Given this list of marker genes Gm5507, Neil3, Hmgn2, Rev1, Zranb3, Bex2, Sncb, Mpp2, D430020J02Rik, Gm22888, Kcnh7, Mcm3, Trp53bp1, Rufy3, Arhgap11a, 4930579G24Rik, Timm50, Zfp239, Tmem132a, Cep85, Mir344c, Rad54b, Aldh1l2, Gm12610, Tdrkh, Hmgb2, Kif20b, Rtel1, Kpna2, Cdca5, Ints7, Pigf, Cibar1, Brsk2, Bcl7a, Ap3b2, Nrm, Agpat5, Trp53i11, Cdc45, Nme1, Fancm, H4c12, Ccdc112, Celsr2 (NCBI Gene Id 53883), Simc1, Chaf1a, H1f5, Myo19, Mtcl3, Ncapg2, Chrnd, Abhd6 (NCBI Gene Id 98228), Fsd1, Jakmip2, Shisa4, Tsn, Rev3l, Cdca8, Cdc25a, Nasp, Nfasc, E2f8, Cenpe, Tonsl, Ndc80, Gm5327, Fancd2, Nup188, Pask, Shcbp1, Yars1, Slc25a4, Mis18bp1, Macrod2, Lrrc40, Rrm1, Sae1, Melk, Ctdspl2, Cpt1c, Dbf4, Eri1, Cnot9, Ddx11, H2ac20 (NCBI Gene Id 319176), Gp1bb, Kif11, Sstr2, Fam120c (family with sequence similarity 120, member C), Plxna3, Cdk1, Mbd4, Prox1os, Pfn2, Ckap2, Pold3, B4galnt4, Aspm, Pgp, Gm16494, Plppr4, Hyls1, Pif1, Dhx9, Brip1, Cdkn2c, Scg3, Tpx2, Cbx6, Ptprn, Rims2, Hmmr, Pold1, Cdkn2d, Mcm6, Rfc5, Pole, Slc35g1, Mir344-2, B930095G15Rik, Gm25432, Rps6kl1, Bdh1, Arfgef3, Lig1, Pmf1, Syce2, Rpa1, Thoc7 (THO complex 7), Adgrb2, Odf2l, Zfand4, Mtf2, Gas2l3, Uhrf1, E2f7, Paxip1, Lhx2, Synpr, Med14, Hells (helicase, lymphoid specific), Pagr1a, Ccne2, Acsl6, Fbxl16, Plk4, Sox12, Cdkn3, Mad2l1, Nuf2, Sox2, Scg5, Ccnb2, Donson, Ubr7, Cdh2, Sez6, Trim37, Gm6625, Hdac3, Ilf3, Dhrs13, Parpbp, Clcn2, Brca2, Foxm1, Cdk2, Dck, Sanbr, Gm13421, Celsr3, Tubgcp2, Ppp2r2c, Cd276, Flywch2, Gm6594, Firrm, Rad51, Tmx1, Cks2, Hint1 (histidine triad nucleotide binding protein 1), Gtf2a2, Smyd4, Tmpo, Tafa4, Cacna1b, Wdr6, Nrsn1, Kif20a, Rfc4, Slc9a5, Jazf1, Kntc1, Syt2, Ccp110, Slc36a4, Gpr173, Tmx4, Gins2, Ttc3, Atp6v0e2, Mcm7, Incenp, H2ac7, Exo1, Vwa5b2, Ppfia3, 2410002F23Rik, 1500009L16Rik, Cep55, Slc6a17 (NCBI Gene Id 99905), Hjurp, Tox, Pkmyt1, Pcbp4, Mapk8ip1, Kif2c, Mmp24, Tfdp1, Ncaph, Unc79, Nrxn1, Srrm3, A230057D06Rik, Cdc25c, Aurka, Cdt1, Coprs, Pdzd4, Entrep3, Ppat, Cdc6, Ccne1, Ranbp1, Rundc3b, Sfxn1, Dcbld2, Uba2, Eid2, Dnmt1, Chaf1b, Gtse1, Rnaseh2b (NCBI Gene Id 68517), Strbp, Prc1, Tpi1, Nmral1, Ahi1, Myb, Myef2, Herc3, Ung, Dock3, Mthfd2, Psip1, Ttc8, Ptprn2, Acvr1, Slc4a8, Pmm1, Ska2, Sephs1, Syt13, Tmem178b, Gm3373, Racgap1, Dtl, Tdg-ps2, Celf4, Kif14, Pcna, Slf1, Asphd1, Tyms (thymidylate synthase), Ptn, Macroh2a1, St18, Slc38a2, Cbx3-ps6, Fanca, Nt5c2, 3000002C10Rik, Nrcam, Atp5if1, Lmo1, Kif23, H2bc13, Syt9 (synaptotagmin IX), Stau2, Pcdhb21, Mboat2, Chgb, Mrps16, Adgrb1 (NCBI Gene Id 97994), Ticrr, Mif, Rundc3a, Eef1ece2, Slain1, Sass6, Scai, Reep2, Mybl1, Hnrnpd, Snrpd1, Arhgef39, Pkm, Msh6, Cenpi, Mcm4 (NCBI Gene Id 17217), Smarcc1, Iqgap3, Srsf1, Cacnb3, H2ac10, Ric3, Dna2, Bex3, 6030442K20Rik, Smc5, Pold2, Prkcb, Anln, Scrn1, Aldh18a1, Klhdc2, Gpr19, Fam216a, Ckap2l, Sbk1, Xrcc6, Caskin1, B4galt6, Gpr37l1, Stx1a, Ctps1, Mir344, Cdk5r1, Mcm5, Gmnn, Prim2, Larp7, Oxct1, Ahcyl, Samd14, Dclk2, H2bc3, Senp1, Cfap20dc, Prelid3b, Pcdhb18, Kcnb2, Myt1, Bub1b, Ankrd28, Suz12, Hmgn2-ps, Rad54l, Nbea, Trpc2, Zfp599, Cadm4, Klhdc10, Rgs17, Kif18a, Morn4, Cenpa, Rad18, Cenpq, Cdkn2a, Syt14, Prox1, Chga, Bicd1, Cisd3, Ppme1, Clspn, H4c18, Gm10313, Zfp382, Blm, Rnu1b1, Ran, Trip13, Nucks1, Eef1a2, Nono, Cdc20, Cep295, Vash2, Nup205, Ncam1 (neural cell adhesion molecule 1), Hirip3, Strip2, Stxbp1 (syntaxin binding protein 1), Ncapd3, Ckap5, Rpa2, Gm10053, Chd7, Pola1, Cntrob, Cenpv, Gpr139, Psd, Clec2l, Kif1a, Nipsnap1, Meaf6, Phtf1os, Slbp, Ttc39aos1, Gapdh-ps15, Rtn2, Kif5c, Ephb2, Hap1, Plppr1, Cspg5, Pidd1, Atad2, Tex9, Cand1 (NCBI Gene Id 76147), Umps, Tube1, Gnaz, Fgf14, Bora, Fanci, Zwilch, Sesn3, Ube2c (ubiquitin-conjugating enzyme E2C), Lhfpl4, Troap, Sfmbt1, Hdac9 (NCBI Gene Id 79221), Tubb5, Rfc1, Srd5a1, Trim59, Ptprz1, Fxyd6, Maged1, Atad5, Msh3, Tmem199, Zfhx2os, Plk1, Gm24837, Sgo2a, Zfp948, Pbk (PDZ binding kinase), Ankrd13b, Elavl3, Dut, 5330434G04Rik, Zgrf1, Gm23293, Ccnb1-ps, Ska3, Cenpl (centromere protein L), Gm22806, Kif22, Lin9, Stil, Spdl1, C2cd5, Snap91, Smarca1, Lrp11, Matcap2, Wdr76, Syt1, Stmn1, Aurkb, Rbm15b, Knstrn, Ska1, Six4, Trmt6, Dhfr, Camsap1, Ncbp1, Gspt2, Cenpm, Rcor2, Phf6, Neurl1b, Ehbp1, Cdk4, Nsd2 (nuclear receptor binding SET domain protein 2, NCBI Gene Id 77281), Map9, Sclt1, Pcyt1b, Aplp1, Morf4l2, Cenpu, Alms1, Apoo, Rbl1, Nphp1, Elapor2, Mapk8ip2, Sarm1, Hsf2, Ina, Uchl1, Abi2, Supt16, Nup155, Smc2, Dpysl5, Tubg1, Gins1, Prr11 (proline rich 11), Cstf2, Map7d2, Hes6, Ints2, Ralgps1, Gm57857, Arhgap19, Zbtb41, B3galnt1, Usp37, Rbfox2, Ezh2, Foxred2, Galnt9, Smc4, Abat, Hook1, Zfp60, G2e3, Scamp5, Depdc1a, Ccser1, Pcdhb17, Mcm2, Zfp114, Prrt3, Faxc, Orc2, Tlcd3b, H1f10, Mki67, Greb1l (NCBI Gene Id 381157), Sez6l2, Cacna2d3, Cbx5, Lancl2, Phyhipl, Th, Zbed3, Fam83d, Ift80 (NCBI Gene Id 68259), A330076H08Rik, Atcay, Fignl1, Gmps, Rgs16, Ctnnd2, Hnrnpa3, Gm6669, Arnt2, Hmgn3, Pcbd1 (pterin 4 alpha carbinolamine dehydratase/dimerization cofactor of hepatocyte nuclear factor 1 alpha (TCF1) 1), Ccnb1, Rimkla, Ddc, Ssrp1, Crmp1, Cenpn, Rnf126, H2bc4, Socs7, Tmem181a, Wnk2, Spag5, Grik5, Ccna2, Kif4, Cdk5rap2, Kifc1, Cenpk, Ccdc138, Pttg1, Parp6, Slc38a1, Ncapd2, Gm5577, Sumo3, Pcsk1, Gm21963, Zkscan2, Fbxo44, Cenpf, H3c3, Irak1bp1, Ccdc18, Tmtc4, Zdhhc2, Casp3 (NCBI Gene Id 12367), Ranbp17, Top2a, Syp, Polr3h, Arc, Birc5, Fmn2, Mtmr7, Exog, Nsl1, H2ac22, Ulbp1, Slc8a1, Helq, Rif1, Dis3, Phf19, Topbp1, Rangap1, Phc1, Orc6, Gm25552, Six1, Tacc3, Foxk2, Ttk, Sertad4, Chn2, Fbxo2, Prmt1, Sobp, ENSMUSG00000134155 (novel transcript, antisense to Nrg3), Cdc25b, Pnma8a, Zfp512b, Gm23557, Rfx3, Sel1l3, Tbc1d24, Depdc1b, Fcho1, Tmem130, Nusap1, Prim1, Dot1l, Bzw2, Pcm1, Gpr75, Nat14, Ncapg, Kdm1a, Kif18b, Gpld1, Dlgap5, Ect2, Gdpd1, Ppip5k2, Jpt1, Efs, Gm3095, Gpr162, Slc7a14, Tipin, Idh3a, Nexmif, Slc45a1, Ano8, Ccn3, Cstf3, Mms22l, Nop58, Plppr2, Ctc1, Maneal, Rcc2, Cenph, Dner, Sgo1, Zdhhc15, Pdxp, Npat, Chrnb2, Rbm15 (NCBI Gene Id 229700), Ptpdc1, Cdkn1a, Wdhd1, Gprin1, Lockd, Pcgf6, Fsd1l, H2ac11, Gen1, Scn8a, Spc25 (SPC25, NDC80 kinetochore complex component, homolog (S. cerevisiae)), H1f0, Cdca2, Rab39b, Gdap1l1, Mir344h-1, Map3k12 (NCBI Gene Id 26404), Rnf112, Nek2, Cdc7, Rragb, Sqle, Chek1, Knl1, Arhgap20, Ipo5, Bok (BCL2-related ovarian killer), Gm23294, here is a description of the gene set: Rb1<F/F>; Rbl1<-/->; Pten<F/F>; Trp53<F/F> mice were generated by breeding Trp53<F/F>; Pten<F/F> mice with Rb1<F/F>, Rbl1<-/-> mice. Mouse Gene Set: LAZARO_GENETIC_MOUSE_MODEL_HIGH_GRADE_SMALL_CELL_NEUROENDOCRINE_LUNG_CARCINOMA_UP studied in species Mus musculus Genes differentially regulated in K5-QKO SCLC tumors from Rb1<F/F>;Rbl1<-/->;Pten<F/F>;Trp53<F/F> mice versus normal lung tissue. from publication Lázaro S, Pérez-Crespo M, Lorz C, Bernardini A, Oteo M, Enguita AB, Romero E, Hernández P, Tomás L, Morcillo MÁ, Paramio JM, Santos M (PMID 31611390)